Given this list of marker genes Htr7, Lrrc41, Rab9, Cul3, Hgs, Ccne1, Vhl, Rhobtb3, Plin3, Rab9b, here is a description of the gene set: Mouse Gene Set: REACTOME_RHOBTB3_ATPASE_CYCLE RHOBTB3 ATPase cycle studied in species Mus musculus